The following is a description of a gene set: Changes in mouse liver mRNA profiles following intraperitoneal cytokine injection. Either interferon-gamma-/-, albumin-cre(-) Socs3(w/fl) mice, or albumin-cre(+) Socs3(-/fl) mice were injected with either phosphate-buffered saline, interferon-gamma, or interfeukin-6, and livers taken after 4h. studied in species Homo sapiens Human Gene Set: GSE369_PRE_VS_POST_IL6_INJECTION_IFNG_KO_LIVER_DN from publication Croker BA, Krebs DL, Zhang JG, Wormald S, Willson TA, Stanley EG, Robb L, Greenhalgh CJ, Förster I, Clausen BE, Nicola NA, Metcalf D, Hilton DJ, Roberts AW, Alexander WS (PMID 12754505) Genes down-regulated in liver from SOC3 knockout: untreated versus IL6 injection., and this is the list of marker genes: TRABD, ST7L, FNDC7, HAPLN2, JAGN1, MORC4, GEM, ENDOG, CHST10, PCGF5, PDCD1LG2, ZNRF1, PRDM10 (NCBI Gene Id 56980), CREBL2, WAC, PAN3, GEMIN5, ZNF664, DLX1, CCR1, RRAS2, TIMM29 (translocase of inner mitochondrial membrane 29), TENT5C, IPO7, OAS2, STX12, SOCS3, PANX1, ZNF251, MANEA, PRKAR2A, TMEM17, TOR1AIP2, ESPN, TRPS1, TCF4, IMMP2L, KMT2A, TRIM25, CCDC117, GALNT10, FAAH, HOXD8, AFG2B, DYNLT2B, ZNF428 (zinc finger protein 428), CACYBP, TMEM184B, HS2ST1, LYST, CTR9, RPE, POU2AF1, GRK5, OAS1, AIRN (NCBI Gene Id 100271873), BTG3, ACADL, OASL, ZNF12, ARL13A (ADP ribosylation factor like GTPase 13A), JPT2, HJURP, FZD5, GPR171, ABCB1, F8, KLHL42, SVOPL, WDR19 (NCBI Gene Id 80203), TSHZ1, PRKDC, ZNF235, FBXO28, THYN1, TRIM65, CNKSR3, JMY, C7orf25, DUSP16, GP1BA, AHCYL2, ATP8B2, ALOX15B, PARP14, SLC39A4, SLC16A9, CELF4, PYGL (NCBI Gene Id 5836), PPFIBP2, METTL8, LYG2, RRAS, ANXA6, TMCO6 (transmembrane and coiled-coil domains 6), DARS2, ZNHIT1 (NCBI Gene Id 10467), ANKRD45, DUSP11, SKA1, PIM2, NCAPD3, P2RY10, FHAD1, LIPH, DNAJB4, NAMPT, ITGB3, BACH1, CFAP298, GRAMD2B, PGLYRP1, CYB5R2, SIMC1, MAP3K5, RNF125, ABCC1, INPP4B, MXD4, NR2F6, SPSB4, MYF5, ENTPD1, ACSM1, PAFAH1B2, FBXW10, DDX60, MX1, CARMIL1, IL6ST, SERPINI1, OSBPL6, SEPTIN14, PRPSAP1, RPRD2, EMSY, ID2, IFT140, LIME1, CCNE1, TRAPPC13, HINT3, PTPN14, CASP9, DNAJB1, ZBTB4, ITM2A, DNAJA1, JAKMIP3, SLC2A1, RGS3, AP1S3, DLC1, KCNG1, SOCS1, CA9, APOE, IFNAR2, UBXN2A, RUFY1, PAPOLA, NKAPL (NCBI Gene Id 222698), DENND11, SPINT2 (NCBI Gene Id 10653), LRRC1, DYRK1A, TMEM41A, DNAAF9, PTPRK, NOTCH1 (NCBI Gene Id 54781), PTK2, PGPEP1L, CTRB2, GPR89B, PEA15, DNAJA4, GIMAP7, NCOA7, KYNU, POGLUT2, ELL3, ANXA4, PLA1A, PDE3B, AURKA, GNPNAT1, IFI30, KLRC1, GPR34, RILPL2, ADM, NT5C3A, APOBEC1, IFIT1B, PRMT2, LRRC2, MX2, CCDC183, TPST2, MARCO